The following is a description of a gene set: Human Gene Set: GOBP_ESTABLISHMENT_OF_ORGANELLE_LOCALIZATION studied in species Homo sapiens The directed movement of an organelle to a specific location., and this is the list of marker genes: PAX6, ARMCX3, BUB3, IGHE (immunoglobulin heavy constant epsilon), PEF1, ACTR10, NUP88, CLN3, KIF1C, HIF1A, BIRC5, TFG, KPNB1, SNCA, SDAD1, TRAPPC2L, PPP6C, NSL1 (NSL1 component of MIS12 kinetochore complex), LMNB1, KNL1, SYT4, MYH10, CHMP4BP1, NTN1, LYN, LIN7C, FAM91A1, SLC18A2, DOCK7, DYNC1I1, MILR1, PARD3B, FEZ1, LGALS9, AGTPBP1, KIF5A, SLC2A4, BORCS7, PMF1, BORCS8, EXOC7, TMED10, TTK, RAN, RMDN1, PREB, MDN1 (midasin AAA ATPase 1), RASGRP1, GPR15LG, LTV1, UNC13A, KNTC1, MYO7A, SMPD3 (sphingomyelin phosphodiesterase 3), XPO1 (exportin 1), BOD1, TSG101, DYNLT1, SPC25, BLOC1S6, RAB11B, HOOK3, TACC2, NSFL1C (NSFL1 cofactor), NHERF1, EIF6, PLA2G3, BBS2, RAB17, GATA2, STAM, ATM, WIPI1, VPS4B, IL13, CDK1, TACC3, GPSM1, INCENP, MREG, RAB24, AP1G1, NDEL1, CDCA8 (NCBI Gene Id 55143), ARHGAP21 (NCBI Gene Id 57584), KIFC1, AURKB, NUSAP1, TBC1D23, F8A3, TRAPPC2B, MARK1, UNC13D, TRAPPC10, CCDC186, TRAPPC9, KIF3B, TRAPPC4, PDZD11, TRAK1, MYO1C, FERRY3, PRKN, TERB1, CHMP4A, RAB7A, DTNBP1, LIN7A, MEIOC, ARFGAP2, ITGB1, ANKFN1, CENPQ, GBF1, INPPL1, TRAPPC13, CCDC66, F8A2, EZR, MRGPRX2, TRIM46, CDCA5, TRAPPC1, OOEP, ENKD1, KIFC2, RIPOR1, PDCD10, VAMP7, LAT, TRAPPC12, ZWILCH, GJA1, TTL, LRRK2, ABRAXAS2, CHMP5, UBE2B, TRAPPC8, AP3M2, SPIRE2, SPIRE1, FAM83D, ARL6, RABGEF1, NEK2, SYNJ1, TRAPPC11, NEFL, MAP4K2, TACC1, SNAP29, DNM1L (dynamin 1 like), NDE1, NDC80, CBL, SPICE1, CUL3, CFL1, MAP1B, RB1, SKA1, CDC42, BLOC1S4, KIF3A, KIF25, PKD1, NUDC, CENPE, DNM3 (NCBI Gene Id 26052), BORCS6, FES, CLMN, UNC13B (NCBI Gene Id 10497), IFNG (interferon gamma), SPAST, CHMP1A, TERF1, KIF2B, STK25, KIF22, PIBF1, KAT5, PLK1, NMD3, SDC1, DNM1, GATA1, FHOD1, SEH1L, RAB6A, AP3S2, MAD1L1, MISP, TOR1A, SDCBP, MLH1, EXOC2, PAFAH1B1 (platelet activating factor acetylhydrolase 1b regulatory subunit 1), SNAP25, SKA3, KIF13A, RHOT2, PDCD6IP, LLGL2, KIF14, ZWINT, APOLD1, RCC2, MGARP, TUBA1A (tubulin alpha 1a), AURKC, MAP2K1, EXOC1, BICD2, CEP120, MYO5A, TSPAN9, CENPA, CDK5RAP2, IRAG2, EXOC8, PDCD6, KIFAP3 (kinesin associated protein 3), CD300A, SPRY1, CDH3 (cadherin 3), MIS12, KIF5B, PCM1, EPCIP, TLE6, HAP1, TMED2, MAP2, NAGLU, ADGRE2, KIF1B, CHMP6, YWHAZ, CHAMP1, BICD1, RAB44, KASH5, EXOC3, BLOC1S3, COPG2, SGO1, RAB27A, CTNNB1, ATP9A, BICDL2, CHMP4C, ESPL1, IL13RA2, PIK3CD, LMNA, SYT11, TMEM230, AP3B1, ITGA4, TRAPPC5, FBXW11, MAPRE1, TCIRG1, NLGN1, CEP83, MX1, CEP19, CADPS, HGS, EXOC4, WDR11, ARFGAP3, F8A1, DYNC1H1, DCTN1, BORCS5, STK11, SCN11A, RPS15, MAPK15, MAP4, CHGA, BBS7, TESK1, TRAPPC6A, SPO11, UCHL1, NUP62, ZNF207, CENPC, CEP55, AP3S1, AP3M1, UBXN2B, PINX1, SNAP23, GRP, AP3D1, KHDC3L, DLG1, S100A13, KIF5C, GPSM2, EXOC6B, KIF28P, CHMP3, PIK3CG, ABRAXAS1, PINK1, KIT, ACTN4, CDK5, MAPT, CLASP1, SPAG5, ANKRD53, LSG1, EML3, SYBU, HTT, PEX14, MAJIN, TERB2, SEC16A, KNSTRN, ASIP, SNF8, BTBD8, KLHL12, LRPPRC, BTK, CDR2L, RHOT1, AP1AR, MKKS, SHROOM2, WASL, SPRY2, UNC13C, KIF1A, NR4A3, AP1M2, FGF10, NLRP5, FCER1G, MAD2L1, TRAPPC2 (NCBI Gene Id 6399), MAP1S, CHMP4B, KIF2C, PARD3, BLOC1S5, PSEN1 (presenilin 1), LMNB2, RRS1, DSN1, SIRT1 (sirtuin 1), CENPF, PSRC1, IKBKG, BICDL1 (NCBI Gene Id 92558), LIN7B, SPDL1, SPG11, NEFH, YKT6, BLOC1S2, PTGDS, SLIT1, STARD3, CD84, GAB2, EML4, COPS5, BLOC1S1, STXBP1, SEPTIN1, GEM, ADORA2B, FYCO1, COPG1, TEX14 (NCBI Gene Id 56155), APC, TMED9, UBB, FOXF1, MYO19, MYH9, ZBED3, MX2, BBS5, HDAC6, EXOC5, HSBP1, CDC23, ZW10, PTGDR, SYNE3, KIF18A, AP3B2, TRAK2, DCTN2, TRAPPC3, PDPK1, SYK, VAMP2 (vesicle associated membrane protein 2), SAR1A, BECN1, DNM2, BAIAP3, NECTIN2, SUN2, TMEM201, SYNE2, LAMP1, SNAPIN, BCCIP, TRIM58, PPFIA2, FGR, MOS, CHMP2A, RAB11A, SEPTIN5, KIF16B, SAR1B, CROCC, MCPH1, OPA1, SIRT2, TRAPPC6B, SPHK2, NOP9, SCRIB, RBM10, SNX6, NPM1, CHMP2B, FNBP1L, VAMP3, CLNK, SDC4, C17orf75, LIMK2, GPR143, CADPS2, CHMP1B, SNX4, RACGAP1, STARD3NL, TANC2, PKHD1 (NCBI Gene Id 5314), CSNK1D, IL4R, KXD1, SAPCD2, CPLX2, LLGL1, CLASP2, SKA2, SPDYA (NCBI Gene Id 245711), MLPH, RAC2, TRIP11, CDT1, KAT2B, NUF2, SPC24, NUMA1, ECT2, ATP13A2, EXOC6, HNRNPU, FMN2, HDAC3, VPS4A, RAB1A, AGBL4, STXBP3, FCER1A (NCBI Gene Id 2205), WASF1, LAT2, RIOK2, RAB3A, VAMP8, STXBP2, CHMP7, UXT, SUN1, KIFBP, CCNB1